Given this list of marker genes Gna14, Ffar1, Plcb3, here is a description of the gene set: electronically inferred by orthology from the curated human pathway studied in species Mus musculus part of: Free fatty acids regulate insulin secretion Reactome Pathway: Fatty Acids bound to GPR40 (FFAR1) regulate insulin secretion This event has been computationally inferred from an event that has been demonstrated in another species.<p>The inference is based on the homology mapping from PANTHER. Briefly, reactions for which all involved PhysicalEntities (in input, output and catalyst) have a mapped orthologue/paralogue (for complexes at least 75% of components must have a mapping) are inferred to the other species.